Given this list of marker genes ZFP62, ZNF638, TPR, SCEL, ARHGAP5, ANKRD1, MAPKAPK2, CDK8, DUSP12, CCL7, LYPLA1, here is a description of the gene set: The tumor suppressor protein BRCA1 has been shown to enhance p53 transcription, whereas activated p53 represses BRCA1 transcription. To further understand the functional interaction of these proteins, we investigated the role of BRCA1 in p53-induced phenotypes. We found that BRCA1 when subjected to forced expression acts synergistically with wild-type p53, resulting in irreversible growth arrest, as shown by VhD mouse fibroblast cells expressing a temperature-sensitive mutant of p53. Furthermore, reintroduction of both BRCA1 and p53 into BRCA1(-/-)/p53(-/-) mouse embryonic fibroblasts markedly increased the senescence phenotype compared to that induced by p53 alone. In particular, we found that BRCA1 expression attenuated p53-mediated cell death in response to gamma-irradiation. Moreover, microarray screening of 11 000 murine genes demonstrated that a set of genes upregulated by p53 is enhanced by coexpression of BRCA1 and p53, suggesting that BRCA1 and p53 exert a promoter selectivity leading to a specific phenotype. Taken together, our results provide evidence that BRCA1 is involved in p53-mediated growth suppression rather than apoptosis. Genes down-regulated in MEF cells (embryonic fibroblast) lacking TP53 and BRCA1 by expression of BRCA1. from publication Ongusaha PP, Ouchi T, Kim KT, Nytko E, Kwak JC, Duda RB, Deng CX, Lee SW (PMID 12802282) Human Gene Set: ONGUSAHA_BRCA1_TARGETS_DN species: Mus musculus